Given this list of marker genes HSP90AA1, SHC1, ERBIN, ERBB2 (NCBI Gene Id 2064), CDC37, KRAS, GRB2, HRAS, PTPN12, NRAS, SOS1 (NCBI Gene Id 7838), here is a description of the gene set: studied in species Homo sapiens Constitutive Signaling by Overexpressed ERBB2 Human Gene Set: REACTOME_CONSTITUTIVE_SIGNALING_BY_OVEREXPRESSED_ERBB2